Given this list of marker genes MAPK1, MTOR, CTPS1, CTPS2 (NCBI Gene Id 95807), GMPS, UMPS, PRTFDC1, RRM1, DPYSL3, URAD, CMPK1, TTR, CRMP1, HPRT1, TYMP, ACP3, PPAT, GDA, CDA, SHMT1, DPYSL5 (dihydropyrimidinase like 5), DPYSL4, DHODH, DPYSL2, ALDH6A1, KDM1A, ADK, CAD, ADA, DPYD, GMPR2, XDH (xanthine dehydrogenase), GART, PAICS, CPS1, PRPS1, GMPR, NT5C2, DPYS, APRT, here is a description of the gene set: The chemical reactions and pathways involving a nucleobase, a nitrogenous base that is a constituent of a nucleic acid, e.g. the purines: adenine, guanine, hypoxanthine, xanthine and the pyrimidines: cytosine, uracil, thymine. studied in species Homo sapiens Human Gene Set: GOBP_NUCLEOBASE_METABOLIC_PROCESS